Given this list of marker genes KAT5, RAD51, MRE11, BARD1, SEM1, DNA2, BRIP1, RAD50, WRN, RAD51C, NBN, RMI2, RAD51D, BRCA1, EXO1, ATM, RBBP8, RAD51B, XRCC2, TOP3A, RMI1, RAD51AP1, BRCA2, BLM, PALB2, here is a description of the gene set: Mutations affecting the C-terminal WD40 domain of PALB2 (amino acids 853-1186) impair its ability to interact with BRCA2, RAD51 and/or RAD51C. In addition, disruption of the WD40 domain can lead to the exposure of the nuclear export signal (NES) and cytoplasmic translocation of PALB2. Mutations affecting the C-terminal domain of PALB2 are more frequent than mutations that affect the N-terminus and have been observed, as germline mutations, in familial breast cancer and in Fanconi anemia, but somatic mutations also occur in sporadic cancers. Cells that express PALB2 mutants defective in BRCA2, RAD51 and/or RAD51C binding show reduced ability to perform DSBR via homologous recombination repair, form fewer RAD51 foci at DSBR sites, and are sensitive to DNA crosslinking agents such as mitomycin C. Reactome Pathway: Defective HDR through Homologous Recombination Repair (HRR) due to PALB2 loss of BRCA2/RAD51/RAD51C binding function studied in species Homo sapiens part of: Defective homologous recombination repair (HRR) due to PALB2 loss of function